Given this list of marker genes DCLRE1C, BCL11B, IPO8, CARD11, RAG1, EPX, ATRX (ATRX chromatin remodeler), WAS, CARD10, CARD9, PGM3, GPR35, PIK3CG, BTNL2, TRAC, NR3C1, EXTL3, STAT3 (signal transducer and activator of transcription 3), JAK1, NLRP1, ZNF341, IL2RG, ELANE, CD3E, CDH23, TCF4, ADA, SRSF2, SREBF1, RNU4ATAC, FOXP3, SLC46A1, RMRP, FAS, IKBKG, CDSN, WIPF1, TCIRG1, USP8, RAG2, LIG4, CAPN3, CASP10, IL6ST, TBX21, PSMB10, NLRP3 (NCBI Gene Id 9558), FASLG, TP53, DOCK8, SEMA4D, ASXL1 (NCBI Gene Id 23393), POLD3, IL7R, CLPB, HLA-DRB1, SLC27A4, MST1, IRF8, USP48, SPINK5, KIT (KIT proto-oncogene, receptor tyrosine kinase), TET2, ZAP70, CHD7, RBM8A, SRP19, CD3D (NCBI Gene Id 915), CD247, GFI1, PDGFRA, STAT6, BRAF, here is a description of the gene set: Abnormal eosinophil morphology species: Homo sapiens Human Gene Set: HP_ABNORMAL_EOSINOPHIL_MORPHOLOGY An abnormal count or structure of eosinophils.